Given this list of marker genes Il5, Adipoq, Mir223, Rbp1, Gfi1b, C1qc, Tesc, Rara, Hax1, Hcls1, Prdm16, Runx1 (NCBI Gene Id 12394), Evi2 (ecotropic viral integration site 2), Zbtb46, Ceacam1, Inpp5d, Cul4a, Lef1, Trib1, Evi2b, Ikzf1, Tescl, here is a description of the gene set: Any process that modulates the frequency, rate or extent of granulocyte differentiation. studied in species Mus musculus Mouse Gene Set: GOBP_REGULATION_OF_GRANULOCYTE_DIFFERENTIATION